The following is a description of a gene set: studied in species Homo sapiens Human Gene Set: GOBP_CELLULAR_RESPONSE_TO_STEROL Any process that results in a change in state or activity of a cell (in terms of movement, secretion, enzyme production, gene expression, etc.) as a result of a sterol stimulus., and this is the list of marker genes: ABCA1, DAG1, RORC, GRAMD1B, LRP8, INSIG1, NFE2L1 (NCBI Gene Id 6937), MIR182, CYP7A1, CES1, INSIG2, INHBA, GPLD1, SMO, DYNAP, MLC1, LRP6, MIR185, GRAMD1A, OSBPL7, PTCH1, RORA, GRAMD1C, INHBB, MIR96, GPR155